Given this list of marker genes PRDM1, DTX3, CCR2, PLAAT3, BUB1, SEC31B, CDCA5, PGC, LIF, GOT1, IL20RB, GJA1, LRP8, GSTT1, ADGRL1, PPP4R1L, P2RY14, CHCHD2, ABI3BP, ATRNL1, TUFT1, TMCO6, AHR, PLA2G10, ARB2A, LYL1, GBP6, CXCR3, SYTL2, ULK4, POU3F3, BRIP1, PSMB9, TDRD7, GJD4, SLAMF6, MIR27A, PCDH20, CHRM4, NELL2, MYH1, DEGS1, ADAM19, UBA2, ICOS, PLS1, LTB4R2, IL5RA, DHX34, NAALADL2, RPSA, SOX2, APTX, CH25H, DSG4, CMKLR1, RNF125, SLC22A13, NXNL1, ACER1, IFNL2, PROK2, SMCO4, CABP2, NDFIP1, DUSP8, CDC16, SYCN, ATP6V0D2, GBP5, SEBOX, FKBP2, MIR211, ENTPD1, DLEU7, ASF1B, LRRC69, TULP3, PHLDB2, OBSL1, LMBR1, CENPH, GABBR1, FOSB, TAAR9, AGMO, DLGAP5, SCN11A, KIR3DL2, WDR27, HSH2D, EEA1, TUBB2B, DOK2, PATE4, ESAM (NCBI Gene Id 90952), LHFPL1, CD320, MARCHF1, TMEM212, NPHS1, SLC17A6, CTLA4, ACTBL2 (actin beta like 2), PEX5, NFE2, KCNT2, ZG16, N4BP1, CCDC89, MIR365B, ABHD16B, DTD1, FAM156A, DGKA, ARHGAP33, DHX58, FUT7, SPACA6, IFNGR1, NLRC5, IL17F, TIGD3, CYP2E1, TSPAN33, ITGB1, KIF5C, HNRNPDL, LY9, ISG15, STX12, TXNDC9, CCDC60, BARD1, RAPGEF5, PDGFRB, CYP27B1, ATP6V1B1, SURF2, TMEM145, DIO2, TASP1, GPRIN2, NCF4, CHRNA9, HOXA9, IFNA5, PAPLN, here is a description of the gene set: Human Gene Set: GSE10147_IL3_VS_IL3_AND_CPG_STIM_PDC_UP We used microarrays to detail the global program of gene expression underlying the effect of p17 on human plasmacytoid dendritic cells and was compared to CpG profile. Genes up-regulated in plasmacytoid dendritic cells: IL3 versus IL3 and CpG. from publication Fiorentini S, Riboldi E, Facchetti F, Avolio M, Fabbri M, Tosti G, Becker PD, Guzman CA, Sozzani S, Caruso A (PMID 18310327) species: Homo sapiens